The following is a description of a gene set: An anomaly of the sternum, also known as the breastbone. Human Gene Set: HP_ABNORMAL_STERNUM_MORPHOLOGY Abnormal sternum morphology studied in species Homo sapiens, and this is the list of marker genes: ADGRG1, WDR19, SYNE2, NOG, GALNS, ZMIZ1, OSGEP, FGD1, TBX6, APC2, IFT140, PDHX, IPO8, METTL27, ITGA7, WNT5A, SPRED1, ELN, MBTPS2, ATG7, TGDS, NXN, SMC1A, PCGF2, GTF2IRD1, NALCN, COL12A1, CHRM3, CSF1R, TGFB2, ZFPM2, HNRNPH2, PLOD2, ARL3, HBA1, RAB33B, SLC25A1 (solute carrier family 25 member 1), KRT5, LMNA, UCHL1, ORC6, LIMK1, SPECC1L, HNRNPH1, CEP120, SDHD, MAT2A, B4GALT7, COG4, HS2ST1, TGFB3, BRAF, PLOD1, RTL1, TCTN3, MEGF10, RFC2, LTBP1, DSE, WNT7A (NCBI Gene Id 7476), CBS, NFIX, MYLK, SLC37A4, GJA8, ACP5, HNRNPK, SLC5A7, LAMA5, PYROXD1, VDR, SPRTN, PIGV, PTF1A, ALPL, RRAS, GPC4, PIEZO1, GNPTAB, G6PC3, TBX5, ACTA2, XYLT2, TRIO, VPS37D, CUL7, ASAH1, AP1G1, WDR35, SYNE1, MFAP5, COL2A1, FHL1, LTBP2, PPP2R1A, UBTF, IRX5, COL11A2, MYOD1, SNAP25, LRP2, PPIB, BUD23, NKX3-2, EXTL3, EBF3 (EBF transcription factor 3), REST, TRMT10A, RAB3GAP2, ABL1, MBTPS1, CRELD1, NKAP, NEU1, TELO2, NF1, CHST3, TMEM94, CPLX1, RBM10, FLNB, NEB, XYLT1, GTF2IRD2, HDAC4, PHEX, ELMO2, SEC23B, NIPBL, GTF2I, RAB5IF (NCBI Gene Id 55969), PPP1R15B, COL5A1, MSTO1, ROR2, NCF1, GLB1, NPR3, PI4KA, IL6ST, PRKG1, GNPTG, MYH11, SLC34A1, CLIP2, PQBP1, EVC, ACTA1, MYL2, ATAD3A, PTPN11, TRIP4, AKT1, IGF1R, ERF, AGA, ESAM (endothelial cell adhesion molecule), SLC2A10, RIN2, FOXE3, TGFBR2, GNPNAT1, FBN1, VPS37A, MRAS, ORC1, BAZ1B, DVL1, RMRP, MAN1B1, ABCC6, IFT172, POLR2A, PIGL, LZTR1, BICD2, GPC3, SEC24D, PIGO, MECP2, FRAS1, RRAS2, LMOD3, NSUN2, EFEMP1, CDC42, EVC2, ANAPC7, SOX10, TBL2, BMP1, DYNC2I1 (NCBI Gene Id 55112), TMEM43, MTX2, KANSL1, SYT2, PTCH1, RNF135, SNX14, VAMP1, PPP1CB, DVL3, DYM, HEY2, SKI, ATP2B1, FKBP6, SLC34A3, MAN2B1, STX1A, PPP1R21 (NCBI Gene Id 129285), ZNF668, RSPRY1, EP300, KLHL41, FARSB, TNNT1, VPS33A, PYCR2, ADAMTSL2, MEG3, DUX4L1, EHMT1, FN1, MARS2, INPPL1, PIGQ, PLAA, TTC21B, CA2 (NCBI Gene Id 760), DLK1, IFT52, RPS6KA3 (ribosomal protein S6 kinase A3), HUWE1, DNAJC30 (NCBI Gene Id 84277), FIG4, TBCK, COL1A2, NSD2, TRIP11, ZDHHC9, ASXL1, PGAP2, GUSB, IFT80, ACTB, RAF1, AMER1, TBX3, DYNC2I2, SMAD3, BGN, CRTAP, BRD4, DHODH, PROKR2, BMP2, KIF7, UPF3B, TRPV4, FBN2, ITCH, GTPBP2, TBCD, CYP2R1, KDM6B, PGAP3, KDELR2, LOX, DUX4, PIEZO2, SPRED2 (sprouty related EVH1 domain containing 2), RAP1B, MAP2K2, PRKG2, SLC12A2, MAP2K1, AHDC1, KAT6A, SOS2, NARS1, AEBP1, EFNB1, SMCHD1, HYOU1, AIFM1, FGFR2, LETM1, MAP3K20, HDAC8, PIGT, HSPG2, IHH, SLC16A2, BMP4, B3GLCT, KRAS, ATP7A, PIK3CA, VPS13B, MYPN, CBL, USF3 (NCBI Gene Id 205717), PIGS, LIG4, NHLRC2, B3GAT3, CSGALNACT1, MME, OBSL1, ATP6V0A2, COL3A1, GATA6, ARID2, ASH1L, MAX, IFT43, LBR, DACT1, CTBP1, FGFRL1, ZBTB20, FBLN5, INTS1, EFEMP2, NRAS, SLC18A3, HES7 (NCBI Gene Id 84667), SOX9, GZF1, PLXND1, SMAD2, FMR1, SIL1, CDC42BPB, FGFR3, ERI1, NOTCH2, PIGY, MAP3K7, RET, DICER1, PLEKHM1, MEGF8, MLXIPL, WBP11, ARID1B, MYH3, NEPRO, TRPM3, HPGD, FRG1, SDHB, FLNA, BICRA, MED25, LONP1, PIGU, KLLN, HRAS, ASPH, SOX5, CCBE1, MYF5, ADNP, SCAF4, NUP107, MGAT2, KDM5C, NAA10, RIT1 (NCBI Gene Id 6016), PUM1, DDR2, COL13A1, MYO9A, PIGW, ZFX, KDM5A, LMBRD2, SRY, SH3PXD2B, CCDC47, LMX1B, TPM2, TGFBR1, RNU4-2, SMAD4, TRAF7, BUB1B, SELENON, LGI3, PACS1, NOTCH3, DPF2, TNFRSF11B, SPTAN1, GORAB, SOS1, CFL2, FKTN, FILIP1, NSD1, PIK3C2A, CTNS, SCN4A, CYP27B1, GJA5, MAPRE2, FRA10AC1, ZEB2, AGRN, MATN3, VAC14, CHAT, HACD1, TUBB, CDH11, CHST11, BCORL1, IGBP1, HSD17B4, SHOC2, MED12, FGFR1, ARSB, CUX1, TAF1, SETBP1, TMEM270, CREBBP, WDR11, TMCO1, MET, TAF6, FZD2, BCOR, FAM20C, SMC3, CHRNG, THSD4, GNB1, PRR12, KIAA0753, TOE1, RAD21 (RAD21 cohesin complex component), SP7, FBXO11, B3GALT6, GDF11, TRPS1, PYCR1, GBA1, NEK1, LRP4, PTEN, SDHC, TPM3, EMD, SCARF2, CHST14, DYNC2H1, SMS, SRPX2, DYRK1A, HBA2, DNMT3B, FKBP10, TNFRSF11A, SLC9A6, RASA2, MAF, PUF60, ALDH18A1, CD96, SIK3, EIF4H, IFT122, KMT2A, DYNC2LI1, FAM149B1, SV2A